The following is a description of a gene set: The chemical reactions and pathways resulting in the formation of folic acid and its derivatives. Mouse Gene Set: GOBP_FOLIC_ACID_CONTAINING_COMPOUND_BIOSYNTHETIC_PROCESS studied in species Mus musculus, and this is the list of marker genes: Atic, Mthfsl (NCBI Gene Id 100039721), Mthfd1l, Gch1, Dhfr, Mthfs, Folr1, Fpgs, Gart, Slc46a1, Mthfd1